The following is a description of a gene set: Human Gene Set: AP4_Q6 studied in species Homo sapiens Genes having at least one occurrence of the motif CWCAGCTGGN in the regions spanning 4 kb centered on their transcription starting sites. This matches the TFAP4 transcription factor binding site V$AP4_Q6 (v7.4 TRANSFAC)., and this is the list of marker genes: ELF4, SOST, FGF8, PTCH2, TMEM125, TRAPPC3, ABHD4, ORAI3, ID3, TMEM255A, DOCK4, TMEM100, TFAP4, NXPH3, TRPV1, ANXA8, APOLD1, CTDSP1, MYLK, HAPLN2, INHA, BSCL2, TCF7 (transcription factor 7), GPR162, TNFSF4, BTF3P11, XCL2, PRKCQ, TEX35, HMGN2, GRK2, CELA3A, HS3ST4, ZNF668, ARHGAP24, RAB3A, TLNRD1, KLF13, UBTF, FOXO4, CHAC1, FMO5, FHL3, CPEB3, WNT9A, FBXO24, PCDH12 (protocadherin 12), PICALM, GOLPH3L, CHRNG, FNDC5, TNNT2, CCDC186, JMJD1C, RAMP2 (receptor activity modifying protein 2), FILIP1, MINDY1, KCNMA1 (potassium calcium-activated channel subfamily M alpha 1), RASL12 (RAS like family 12), TRPC4, RAB27A, GOLM2, RIPOR1, HOXC12, CELF3, HID1, RUSC1-AS1, ZMIZ1, RBMS3, PRKACA, LCK, TMOD4, NANOS1, PLXNB3, ABLIM1, ARID1A, ZRANB1, KCNE5 (potassium voltage-gated channel subfamily E regulatory subunit 5), SCAMP5 (NCBI Gene Id 192683), MYBPH, RPL23AP32, KCNN2, GAS7, WNT2B, NDUFA4L2, LINC00482, CSDE1, BICRA, WDTC1, DLL3, CACNB2, LDLRAD3, SLC25A35, EPOR, HOXB5, EYA3 (EYA transcriptional coactivator and phosphatase 3), MYL6B, PRICKLE1, ZBTB18, KCNQ4, SOX12, ASB16, MUC15, CBX6, KIRREL2, MIR9-1HG, CADPS, FGF12, DHRS3, ESRRA, STARD13, CREB3L1, PHF23, PPM1J, MAST1, SPTBN1, GNB3, LRRN2, BACH1, NDST2, TMOD3, RUNX1, HOXC4, LAT, C1orf116, NPPA, PITX3, ZNF385A, WDPCP, SYTL1, PHLDB1, CFAP65, PDE3A, GRIN2B, RASGRF2, SYVN1, HSD11B1, TPM3, AIF1L, PTPN7, FOXD3, FOSL2, TRAF4, RAB30, EMILIN3 (NCBI Gene Id 90187), KSR2, EPHA2, SPOCK2, VAMP3, NES, VGF, CHID1, MAP3K13, CNIH2, ARHGEF2, TMEM182, ERN1, HOXA6, CBFA2T3, AZIN1, SORBS1, AMPH, CHMP4B, AICDA, PROK2, UBALD2, SUV39H2, RPS6KB1, FBXL21P, OBSCN, GRIK3, WNT4, OLFML1, IKZF2, COL7A1, ZNF646, HJV, VPS45, ZSWIM8, TRIM62, CLEC4D, SIX5, RASGEF1A, FBXO40, GOLGA2P11, STOML2, BCL11B, FRAS1, MARCHF5, RGS7, GNG3, CACNA1G, OR10J1, RASL10B, TXNDC12, KDM2A, ASB5, PABPC5, LURAP1L, HDAC4, NEUROG3, RTKN, VAT1, LBX1, PTK7, CLEC14A, LOXL4, MID2, ARNT, SYTL2, ZNF398, PGF, PTPRS, SMARCA2, EMP3, BCL2L2, RXRG, EYA1, ABTB2, INPPL1, XPNPEP1 (X-prolyl aminopeptidase 1), CNNM2, GATA3 (GATA binding protein 3), PCYT1B, PARP6 (NCBI Gene Id 56966)